Given this list of marker genes Map1a, Mapk8ip3, Kif5b, Kif3a, Kif5c, Dlg2, Kif5a, Neto1, Hspb1, Myo5a, Rab27b, here is a description of the gene set: studied in species Mus musculus The directed movement of proteins along microtubules in neuron projections. Mouse Gene Set: GOBP_AXO_DENDRITIC_PROTEIN_TRANSPORT